The following is a description of a gene set: from publication Schaefer CF, Anthony K, Krupa S, Buchoff J, Day M, Hannay T, Buetow KH (PMID 18832364) species: Homo sapiens Ceramide signaling pathway Human Gene Set: PID_CERAMIDE_PATHWAY, and this is the list of marker genes: MAP3K1, TRAF2, RAF1, FADD, BCL2, AKT1, KSR1, MAP2K4, MAPK1, EGF, MAP2K1, BID, MAP2K2, ASAH1, SMPD3, NFKBIA, BAG4, RIPK1, CASP8, PRKRA, PAWR, CRADD, BAD, SPHK2, MAP4K4, CTSD, NFKB1 (NCBI Gene Id 4790), BIRC3, MAPK8, RELA, AIFM1, EIF2AK2, TNF, PRKCD, SMPD1 (NCBI Gene Id 6609), CYCS, MADD, MAPK3, TRADD, PDGFA, BAX, PRKCZ, MYC, TNFRSF1A